The following is a description of a gene set: studied in species Mus musculus from publication Chen Y, Wang X (PMID 31504780) Genes predicted to be targets of miRBase v22 microRNA mmu_miR_7682_3p in miRDB v6.0 with MirTarget v4 prediction scores > 80 (high confidence targets). Mouse Gene Set: MIR_7682_3P, and this is the list of marker genes: Rusf1 (RUS family member 1), Gm3558, Atat1, Akirin1, Pard3b, Acer2, Rora, Gm2897, Eya1, Cdc40, Tmc7 (NCBI Gene Id 69500), Ube3d, Ywhaz, Zfp329, Ramp2, Me3, Amd2, Irx2, Stxbp1, Map1lc3b, Rhoa, Casp2, H2-M5, Rims2, Aff1, H2ab3, Ppil2, Gml2, Nectin1, Pdxk, Ubn2, Trpc4, Sim1, Nr6a1, Rab43, Dab1, Tcf7, Ebf2, Stk35, Scaf4, 4930555G01Rik, Sox7, Gpm6b, Nkain1, Tnfaip1, Idh3b, Ormdl3, Gm3411, Tsc1, Armc9, Gcnt7, Bptf (NCBI Gene Id 320433), Pip4k2a, Stox2 (storkhead box 2), Zfp128, Zscan21, Gml, Gm10406, 4930523C07Rik, Sfxn4, Arrb1, Ammecr1l, Gm3696, Gas7, Manba, Wars1, Xylt2 (xylosyltransferase II), Maip1 (NCBI Gene Id 98197), Slc24a2, Eml6, Dab2ip, Chmp6, Scai, Mtres1, Myo9a, Smarcd1, Igdcc3, Gm3500 (NCBI Gene Id 100503806)